Given this list of marker genes GP6, DDR1, ITGA2 (NCBI Gene Id 3673), OSCAR, DDR2, ITGA11, here is a description of the gene set: Human Gene Set: GOMF_COLLAGEN_RECEPTOR_ACTIVITY Combining with a collagen and transmitting the signal from one side of the membrane to the other to initiate a change in cell activity. studied in species Homo sapiens